Given this list of marker genes XKRX, MAFF, SRSF7, TMTC2, ENTPD1, SEMA7A (semaphorin 7A (JohnMiltonHagen blood group)), CADM1, PRL, C12orf50, PITX2, DCDC1, KIAA0825, NSMCE3, ELAVL4, LHX6, PCDHGB7, NLK, MEIS2, HOXB9, EYA1, FOXD3, COL13A1, CCDC8, PPP1R10, CCDC91, MUSK, ANKRD46, FGF13, DAZL, ERG, TAS2R7, C1QTNF6, SOX4, NRP1, MAP3K20, VGLL3, LGI2, USP9X (NCBI Gene Id 8239), MARCKS, OLIG3 (NCBI Gene Id 167826), SOX12 (SRY-box transcription factor 12), THRA, ESRRG, POU2F1, ACVR1, RGS1, PPP2R2B, MYBPC1, CASK, TSHZ2, FAP, JADE3, RELCH, SOBP, ZNF654, HOXC6, KLHL13, GAB2, C12orf57, YRDC, POU3F4, PCF11, PPP1R14C, HOXB8, DUSP6, USP25, PTCH2, PLAG1, UBE2Z, HHIP, ASPN, ZFHX3, PRSS35, PCDH18, AP1G2, CDIN1, SKA2, DLG2, RHEBL1, RBFOX2, CPEB4, SLC39A13, ASIC2, ATP1B1, GBX2, MANF, CEP120, R3HDM2, DOCK7, ETV5, ZBTB9, MRPS23, ELAVL2, BDNF, NSG2, ADGRL1, VAMP3, BCL11A, C20orf204 (NCBI Gene Id 284739), CSAD, HOXA4, WNT8B, PRR11 (NCBI Gene Id 55771), KRT9, PRDM8, TMCC2, SIAH3, IGSF9B, FGF7, SERTAD4, ZDHHC23, NEUROD6, TDRD5, CCDC33, SCN3A, CITED2 (NCBI Gene Id 154106), TMTC1, TEAD1, SALL1, FEZ1, HOXB6, ZNF385B, PRR34, INHBA, OTX2, NPR3, TENM1, HPN, VKORC1L1, GNAO1, FGFR3, FAM50A, HOXA2, MBNL2, RIPK4, CCND1, EPHA7, CNTN6, CSRNP3, HTR2C, UBE2K, NEUROG1, HOXD3, CHD2, FGF9, TPM1, PI4KA, NGLY1, MYL1 (NCBI Gene Id 90307), GPX1 (NCBI Gene Id 2876), PMCHL1, SMPX, ITGA8, JADE2, SPAG5, IBSP, MPPED2, DRG1, MXD4, FOXP2, ENSG00000255537 (novel transcript, antisense to FEZ1), HIVEP1, PSMD1, ELOA2, HOXA3, MRPS18B, BRAF, DCHS1, WBP1, CACNG2, IL1RAPL1, SGK3, INPPL1, ZNF521, SEMA3A, TSHB, STXBP5 (NCBI Gene Id 134957), OPCML, LDB2 (LIM domain binding 2), NANOS1, PAX2 (NCBI Gene Id 5076), RTN4RL1 (reticulon 4 receptor like 1), TCEAL8, DSCAM, RORA, HOXB5, LRRFIP2, CSMD3, CCIN, PGAP3, CACNA1C, TP63, INO80D, KRTAP13-1, EHF, TBC1D21, ARHGAP44, ST13P4, CAST (NCBI Gene Id 831), C1orf122, MIR137HG, MID1, CHN2, SLITRK2, FXR1, MEIS1, CNTNAP4, SLITRK1, TWIST1, FAM53B, PURA, NOG, PAX6 (paired box 6), NPM3, HOXB3, BAZ1A, PHACTR3, BEND4, ANKS1B, GDI1, IL25, RRAGA, MTF2 (metal response element binding transcription factor 2), ZKSCAN4, ADAMTSL1, EN2, ID3 (NCBI Gene Id 3399), RNF213, TENM3-AS1, PMCH, JUNB, OSBPL7, TENT4B, RSKR, EIF4A1, CARTPT, HOXA9, SLC7A8, EIF2B3, here is a description of the gene set: species: Homo sapiens Human Gene Set: PIT1_Q6 Genes having at least one occurrence of the motif NMTTCATAAWTATWNMNA in the regions spanning 4 kb centered on their transcription starting sites. This matches the POU1F1 transcription factor binding site V$PIT1_Q6 (v7.4 TRANSFAC).